Given this list of marker genes MECP2, HDAC4, AVPR2, CEP120, ARX, TBC1D24, NR1H4, HPDL, TP53RK, PRR12, ANO1, MID1, TUBB, ARHGEF9, PEX26, IBA57, NXN, KRT71, IFT74 (intraflagellar transport 74), TRAPPC14, DLG5, KDSR, ADNP, LRRC56, GATA4, THOC6, RPL15, KRT5, ADAMTS3, PITX3, PPIP5K2, BRPF1, PEX19, EBP, MARS2, ADAMTS2, RAB3GAP1, ACVR1, PRMT7, SPIN4, BBS9, AP4B1, SALL1, VSX1, ATPAF2, ARHGEF2, OSGEP, PEX14, GJA8, SEC23A, TMIE, TSEN54, NOG (noggin), EDNRB, GATA5, PLCB4, SOX10, KMT2D, ASNS, STRC, TENM3, DPAGT1, TMEM107, SPTBN4, SFXN4, POMGNT1, GTPBP3, EIF3F (eukaryotic translation initiation factor 3 subunit F), PI4KB, CYP2U1, MKKS, BBS5, WAS (NCBI Gene Id 7454), CRYBA1, CIB2, SLC25A24, RAB18, CHST14, CDC14A (NCBI Gene Id 8556), GRHL3, POMT1, NRAS, ELP2, EGFR, ADSL, GPRASP2, CLRN1, EDN1, AMPD2, TGFBR1, ADAMTS19, COL18A1, KRAS, GDAP1, TRPM3, DCPS, COLQ, DLL4, PDHX, HRURF, SVIL, ATR, ERGIC1, ERCC1, KANK1, KYNU, FOXC1, KCNQ1, ACTG2, ACAD9, HPS6, COX5A, MRPS22, NIN, F13A1, NDUFA6, ATP2B1, CLDN10, SMG9, HNRNPH1, FOXRED1, KIAA0825, EXOC6B, BRD4, GATA3, TRAF7, SLC37A4, TSEN15, PKHD1L1, TAF1, KNL1, CEP152, SASS6, ARMC9, AARS2, ALX4, TUBB1, RNF13, MAB21L1 (NCBI Gene Id 4081), TMEM216 (transmembrane protein 216), EN1, ATCAY, MEGF10, TCTN2, ITGA7, PXDN, DOLK, DOCK11, UBE3B, ATP11C, TUBB4B (tubulin beta 4B class IVb), KIAA0586, MYCN, COL25A1 (NCBI Gene Id 84570), HNRNPR, MITF, AP1B1, XYLT2, CHRNE, CNOT1, MEGF8, LAMA3 (NCBI Gene Id 3909), ABCD4, PKLR, RPL10, FANCL, NAA10, SREBF1, TBX5, RPS10, TMEM98, SMC1A (NCBI Gene Id 8243), DPH5, PIGA, ADCY6 (adenylate cyclase 6), GFRA1, PPP2R3C, SCAF4, WLS, PLEC, TGIF1, MSRB3, ATAD1 (ATPase family AAA domain containing 1), NPHP1, AEBP1, DYNLT2B, CPLANE1, AFF4, KIF15, TTC7A, ATP2B2, TCF12, ALOXE3, TUBGCP6, RARS2, CYP19A1, NDE1, STS, LMNB2, IGF2, FBN2, RECQL4, TSR2, DTNA, STIL, ECM1, PIGY, CAPN15, SERPINE1, PLAA, SLC5A7, PRKACA, NUP155, PDGFRB, TUFT1, DNASE2 (deoxyribonuclease 2, lysosomal), EXOC7, H4C3, AGTPBP1, VANGL1, ERCC3, MKS1, CNTNAP1, ENPP1, MED25, SLC12A2, FOCAD, UROS, SF3B4, EEF1A2, POMP, SNORD116-1 (small nucleolar RNA, C/D box 116-1), HBG2, CEP63, COL4A1, LARGE1, TUBB3, LEMD3, ALG8, CCNQ, PEX10, INPPL1, NOP10, RHOA, NODAL, ALOX12B, ZFYVE19, RNU12, RYR1, INSR, UBE2T, MYH9, HOXB1, NKX2-5, BCS1L, HDAC9, ERCC4, SOX18, MINAR2, ATP2A2, DCHS1, POLR1C, DNMT3A, NIPAL4, GJB2, DSG1, SOX2, PGAP2, TRMT10A (tRNA methyltransferase 10A), SUFU, JAG1, ABCB6, PRUNE1 (prune exopolyphosphatase 1), TMC1, MPZ, NEK9, LRP5, NDUFAF4, AARS1, LMOD2, KITLG, MYO6, TPM3, SCNM1, TRIM44, STX5, ASXL1, SELENON, BSCL2, RARB, NUP37, WT1, BLM, MARK3, ITPR1 (NCBI Gene Id 619543), BLTP1 (NCBI Gene Id 84162), DNMBP, XRCC2, F13B, RFWD3, HSPG2, SLC26A2, DSE, MYL11, SCARF2, HCN4, ATP6V0A2 (NCBI Gene Id 7854), BCL11A, PSMD12, LAMB2, EML1, VAX1, CACNA1A, FKBP10, ROBO3, PEX2, DNAAF3, TNNC2, SLC25A19, KCNE1 (potassium voltage-gated channel subfamily E regulatory subunit 1), WDR35, ASXL2, DRG1, SMO (smoothened, frizzled class receptor), SLC4A10, IFT56, COA5, CWF19L1, COL11A2, JUP, COA6, LMOD3, SIAH1 (NCBI Gene Id 6477), LRPPRC, BRF1, ASPM, GDF11, ELOVL4, MYO15A, NCAPD2, DNAH9, PNPLA1, SPECC1L, NKX2-1, CRYBA2, TYMS, STAG2, CEP295, KIF5A, PLK4, ITGA8, ANOS1, VSX2, SERPINB7, LAMA2, GORAB, AP3B2, NOTCH3, MYH3, FLG2, BAP1, NUP88, PSAP, NECTIN1, PWAR1, BPNT2, WNT5A, CLMP, RPA1, MAP3K20, POLA1, HBA1, LAMC2, DOCK6, ECE1, MTO1, DMXL2, IPO8, STAC3, SATB2, CHST3, GATA6, ALAD, FGG, SRD5A3, PIGN, COL7A1, COQ7, SYT2, LRTOMT (leucine rich transmembrane and O-methyltransferase domain containing), AHDC1, NECAP1, ALG3, TCOF1, COL6A2, ATP2B3, FGFR1, ZBTB7A, EXOSC9 (NCBI Gene Id 5393), KY, ATOH7, GTF2H5, SULT2B1, PAX6, CHD7 (NCBI Gene Id 780907), SIK3, POLR3A, PHOX2B, FGFR2, LHFPL5, CST6, ZIC1, FUT8, IRX5, CDK5RAP2, DBH, CWC27, RBM10, DHCR7, NBN, HSD3B2, CC2D2A, TKT, IARS2, BCAP31, CYP4F22, NCAPG2, EIF5A, QRICH1, DYRK1A, HMBS (hydroxymethylbilane synthase), GUCY2C, F2, IGHMBP2, FGB, RPS19, CSF1R, JAM3, TXNDC15, MYL1, INPP5K, MYF5, CTSD, PLD1, SNRPB, VPS35L, CCDC103, BMP1, EPHB4, RFX6, NECTIN4, TMEM70 (NCBI Gene Id 54968), KIFBP, STAG1, GMPPB (GDP-mannose pyrophosphorylase B), EOGT, TCTN3, COG4, VLDLR, COL1A2, PUF60, PAX2, MCPH1, PLCD1, PORCN, H1-4, KCNJ6, AGPAT2, GJB4, MYO9A, FOXI1, YIF1B (Yip1 interacting factor homolog B, membrane trafficking protein), GOSR2, SF3B2, ABCA3, RNU4ATAC, ACVR2B, VARS1, SMAD2, DPYD, FIG4, COX6A2, MAPRE2, GRIN1, PKP1, TAB2, LPAR6, COG7, NPHP3, NF1, KCNK4, ABCB7, SLC25A4, TASP1, MAB21L2, GLS, ASH1L, MDFIC, ALDH3A2, TPM2, POMK, FAM111A, TARS2, GRXCR1, OTOF, HERC2, HAAO, CAV1, CDK13, NPHS1, ORAI1, EDN3, EP300, TMCO1, ATN1, MICOS13, TGFBR2, RERE, ATIC, GFM1, FOXE3, ITGB4 (integrin subunit beta 4), TRPV4, SCN11A, TXN2, DICER1, COCH, BUB1, TUBA1A, PIEZO2, KIAA0753, CRELD1, DCT, GMPPA, NDUFB11, ATOH1 (NCBI Gene Id 474), THPO, NUAK2, BBS12 (NCBI Gene Id 166379), PCLO, MNX1, CFAP410, FZD5, ALMS1, COL6A3, LSM11, CD164, FAM111B, CASK, ZMPSTE24, MAF, CLCNKA, HMGB3, SALL4, PDX1, PPP3CA, MOGS, ELP4, MYBPC1, SMARCAL1, GJA1, ALDH1A3 (aldehyde dehydrogenase 1 family member A3), KIF26A, SLC6A9 (NCBI Gene Id 6536), PITX1, POGZ, CDK10, BRWD3, PWRN1, KRT85, CEP135, COQ4, DEPDC5, SMARCC1, ELP1, DNA2, TMEM106B, HERC1, DPM2, RPGRIP1, ORC6, SPTAN1, PTCH1, PIK3CA, CCDC28B, CFAP53, FGFR3, CALM3, HRAS, FTO, COG1, CAPRIN1, BHLHA9, RAB3GAP2, MTMR14, WARS1, HS2ST1, TBC1D23, ERCC6, OFD1, BCL11B, FLVCR2, RBBP8, DOHH, TMEM132E, OPA1 (NCBI Gene Id 4976), IGF1, NEK8, TSEN2, MED23, LAMB3, ARL2, LIFR, COL2A1, SDHB, ANKH, EGR2, PIGF, GLI1, GCSH, LRP4, FTH1, U2AF2, ALPK3, COL13A1, ERF, GSC, ESRRB, TLK2, SCO2, OCRL, OTOGL, EPG5, TYR, AP4E1, FBLN5, TSPEAR, TRIM32, ODAD3, MAPKAPK5, COL3A1, SSR4, CRIPT, ESCO2, LAMA5, COL4A6, MEIS2, FOSL2, POLR3B, CCDC39, ATP6V1B2, SIX6, PAM16, BRAF, CRYBB3, CYB5A, CCND2, DNM2, CRYGB, NRIP1, GAS2, POLE, TWIST1, TULP1, SLC25A12, CFL2, HK1, LBR (NCBI Gene Id 653311), LZTFL1, TRIP4, ITGA6, TBX2, CTCF, CBX2, MAP3K7, TWIST2, EFEMP2, AP4M1, ZNF148, NUS1, EPS8 (EGFR pathway substrate 8, signaling adaptor), ADGRG1, DTYMK, RALA, KCNA4, RAP1B (NCBI Gene Id 5908), GNPNAT1, ACTA1, TLL1, KATNB1, KAT6A, ATP6V1E1, ORC1 (NCBI Gene Id 4998), GSX2, OTOG, MPV17 (mitochondrial inner membrane protein MPV17), LSS, NSUN6, FGF16, GNPAT, CDK6, AP3B1, PREPL, KARS1, ACTB, BMPR1B (NCBI Gene Id 658), FGF3, MCM3AP, SMARCD2, RIPK4, SCN8A, UBA2, CENPJ, MAMLD1, SLC39A8, ATP6V1A, HCCS, FANCC, GLI2, PYROXD1, IFIH1, ZIC3, RAD51C, PSMB10, COX7B, IFT140, SLC26A4, ZSWIM6, HOXD13, UBA5, PCDHGC4, SLC6A6, CD8A, TRIM36, PRKACB, ACP5, RNF113A, RAD51, CIT, TNNT1, PC, LZTR1, NPAP1, COL17A1, DCDC2, NSDHL, PRDM13, IER3IP1, PSAT1, CHRNB1, PDCD6IP, C1QBP, SCN5A, VPS33B, EIF4A3, PEX3, COL1A1, NR2F2, SLC16A2, NALCN, CTU2, RPGRIP1L, YY1, GDF3, KAT5, DSTYK, KATNIP, BBS2, NDUFA4, IRF6, CLCN7, MAX (NCBI Gene Id 4149), UBR7, GPR156, RMND1, TBCD, LARS2, KCNN4, HIVEP2, POLR1D, AMHR2, FLNB, NOTCH1, CFAP45, GLI3, NRCAM (neuronal cell adhesion molecule), IFT122, LMBR1, HPGD, CHRNA1 (cholinergic receptor nicotinic alpha 1 subunit), ATP1A3, RPS28, C2CD3, SOX9, TFAP2B, CA8, TRPS1, ANKS6, PPFIBP1, GFM2, FOXI3, FKTN, FANCF, CREBBP, YRDC, TNNT3, PCDH15, KRT1, FZD6, MBTPS2, MYO7A, REEP1, IQCE, SPI1, MAGEL2 (MAGE family member L2), CCDC88A, ATP9A, CCDC32, ACTA2, ZC4H2, COPB2, SPRED2, HELLS (helicase, lymphoid specific), KIF7, TBCE, POMGNT2, FIBP, NIPBL, RRP7A, EXOSC3, RXYLT1, ECHS1, LRP2 (LDL receptor related protein 2), FKRP, DHH, CDC40, C18orf32, MUSK, EDNRA, GLDN, TTC5, CITED2, WHRN, WDR19, TMEM231, CFC1, ABCC9 (ATP binding cassette subfamily C member 9), TSHR, PPP1CB, TAMM41, ERCC2, ERI1, SPINK5, LMNA, PSMC3, CAMK2B, BBS4, CREB3L1, PTRH2, TBCK, ASCC1, CATSPER2, KIF1A, MPC1, BLOC1S3, EPS8L3, PDE4D, CDK5, NARS1, POP1 (POP1 homolog, ribonuclease P/MRP subunit), MYH2, B3GALNT2, FGF10, CDH11, OTUD5 (OTU deubiquitinase 5), SNF8, VIM, WDR81 (NCBI Gene Id 780925), MKRN3, MPDZ, CDC45, IFT27, ZIC2, YAP1, TXNL4A, GLRB, RUNX2, ZFPM2, HOXC13, PDE6D, CRYAB, RSPH3, IFT52, TGDS, GDNF, SNORD115-1, SIX3, PAX8, IGBP1, PRKD1, KLF1, EXTL3 (exostosin like glycosyltransferase 3), TBC1D20, CDAN1, MATN3, ACKR3, GP1BB, CHMP1A, CDC42BPB, HYCC1, ECEL1, BSND, SNUPN, ANKLE2, PEX5, COLEC11, PALB2, NCAPH, LFNG, KCNJ10, FGA, ROBO1, CHUK, ORC4, STAMBP, TBC1D8B, TP63, PHGDH, CD320, PAFAH1B1, MRPS16, GP1BA, FREM1, TRAPPC12, HOXA2, ELN, MYSM1, SUMO1, NPR2, PIGT, AGK, RBM8A, RPL27, ZBTB24, DPH1, KRT10, TGM1, LIPH, AXIN1, HECTD4, IKBKG, PLXND1, UGT1A1, WDPCP (NCBI Gene Id 51057), PKD1L1 (NCBI Gene Id 168507), GNE, COG6, LONP1 (NCBI Gene Id 9361), RNH1, PPIB, GGPS1, AFG2B, ATP5F1A, ALG9, USP48, TPM1, OPN1MW, FYCO1, SCN4A, TOE1, AR, ARL6, FLNA, DDX59, GLE1, ABCA12, GEMIN5, FILIP1, DDX11, FAM20C (FAM20C golgi associated secretory pathway kinase), DPP6, COL11A1 (NCBI Gene Id 317718), BBS1, EED, AKT2, RMRP, PTPRJ, EFEMP1, ZBTB20, POMT2, GDF5, WNT10A, MET, CACNA1D, MFSD2A, NHS, PYCR1, EXT2, DONSON, DLX5, ALDH18A1, RAPSN, MED11, CHAMP1, TELO2, DSG4, TUBGCP4, RRM2B, NKX3-2, UNC45B, HEPACAM, CERS3, MC2R, DCC, RBPJ, SLC2A10, PAX3, RSPO2, CDCA7, SLITRK6, TMEM94, MIP, WDR62, MARVELD2, ZNF141, PRKAG2, LTBP4, H4C11, SMAD6, RIPOR2, FOXE1, FAT4, SLC35A3, TBX6, SYNE4, RPS26, PHOX2A, SDR9C7, TTC8, SMOC1, ZNF335, SAMHD1, RUSC2, B4GALT1, IGF1R, BICD2, FZD2, CENPF, GREB1L, ABL1, FREM2 (NCBI Gene Id 341640), STRA6, VRK1, NUDT2, DSP, AMH, PMM2, CSPP1, POLR1A, G6PD, HES7, EXOC2 (exocyst complex component 2), KLHL24, BIN1, ATP8A2, CLCNKB, CHAT, TMEM67, CRYBB1, PIGO, CDC6, IFT172, AP1S1, TRPV6, ROR2, FBN1, AFG2A, TBX3, KRT14, SCN9A, CDH3, LTBP1, TMPRSS3, PKHD1, PRKAR1B, KRT74, CDT1, KDM6A, AGR2 (anterior gradient 2, protein disulphide isomerase family member), SC5D, C2orf69, CABP2, ADAMTS15, WDR4, SELENBP1, NEDD4L, ITGA3, FLT4, CBFB, CLPB, GUF1, ST14, PEX12, CIROP, DVL1, FANCI, SIN3A, GP9, PRPS1, ARCN1, SHMT2, KLK11, here is a description of the gene set: Congenital onset A phenotypic abnormality that is present at birth. studied in species Homo sapiens Human Gene Set: HP_CONGENITAL_ONSET